Given this list of marker genes GUK1, NME2, IMPDH2, VAV2, TPMT, RAC1, VAV3, SLC28A3, VAV1, XDH, NUDT15, GSTM1, ABCC4, GMPS, SLC29A2, ABCC5, HPRT1, IMPDH1, SLC29A1, SLC28A2, NME1, GSTA1, GSTA2, here is a description of the gene set: part of: Drug ADME Reactome Pathway: Azathioprine ADME studied in species Homo sapiens Thiopurines were originally developed for cancer treatment in the early 1950s, with 6-mercaptopurine (6MP) being the first thiopurine approved by the FDA for the treatment of leukaemia, just two years after its discovery. Azathioprine (AZA), a prodrug of 6MP, was developed by the addition of a nitroimidazol group a few years later to bypass the high first-pass metabolism of 6MP due to oxidation in intestinal cells by xanthine oxidase (XDH). AZA is a thiopurine prodrug, and its pharmacological action is based on the release of the active metabolite 6-mercaptopurine (6MP) which is further metabolised to pharmacoligically active 6-thioguanine nucleotides (6-TGNs). These 6-TGNs achieve their cytotoxic effects in one of four ways<br><br>1. Incorporation of 6-thioguanosine triphosphate (6TGTP) into RNA<br>2. Incorporation of 6-thiodeoxyguanosine triphosphate (6TdGTP) into DNA<br>3. Inhibition of de novo purine synthesis by methylmercaptopurine nucleotides such as methylthioinosine monophosphate (meTIMP)<br>4. Inhibition of RAC1 by 6TGTP which induces apoptosis in activated T-cells.<br><br>While AZA has been supplanted as an antitumour drug, it remains useful as an immunosuppressant antimetabolite drug indicated to treat rheumatoid arthritis, Crohn's disease, ulcerative colitis, cancer and to prevent rejection in kidney transplant patients.<br><br>The molecular steps of AZA metabolism are described in this pathway. Briefly, oral AZA is rapidly converted to 6MP. Initial 6MP metabolism occurs along competing catabolic (XDH, TPMT) and anabolic (HPRT) enzymatic pathways. Once formed, 6-thiosine 5′-monophosphate (6TIMP) is further metabolized by inosine monophosphate dehydrogenase (IMPDH) and guanosine monophosphate synthetase (GMPS) to 6-thioguanosine 5′monophosphate (6TGMP). 6TGMP is then converted to the pharmacologically-active di- and tri- derivatives by their respective kinases.